The following is a description of a gene set: The directed movement of a protein to a specific location in a plasma membrane. Mouse Gene Set: GOBP_ESTABLISHMENT_OF_PROTEIN_LOCALIZATION_TO_PLASMA_MEMBRANE studied in species Mus musculus, and this is the list of marker genes: Rab11a, Scrib, Optn, Rab10, Sptbn1, Trarg1, Grip2, Amn, Atp6ap1, Akap5, Rilpl2, Nectin3, Csk, Acsl3, Phaf1, Arl6, Nsg1, Golga4 (golgin A4), Rab7, Gga3, Lrrc7, Pkdcc, Vamp2, Cln3, Gripap1, Ank3, Kif13a, Arhgap44, Gga1, Lyplal1, Rab34, Blzf1, Golph3, Rab11fip3 (RAB11 family interacting protein 3 (class II)), Bbs1, Rack1, Prepl, Lypla1, Sorl1, Atp2c1, Snx27, Vamp4, Zdhhc2, Afdn, Cnst, Rab31, Bbs2, Rab26, Golph3l, Gga2, Vps35, Krt18, Rilpl1, Nsf, Scarb2, Gorasp2, Grip1, Arfrp1, Vamp3, Myo5b, Gorasp1, Commd1, Rdx, Rab8a, Washc1, Sys1, Golga7, Vamp5, Macf1